The following is a description of a gene set: Human Gene Set: GSE11961_MARGINAL_ZONE_BCELL_VS_GERMINAL_CENTER_BCELL_DAY7_DN To obtain insight into the genetic basis of the increase of functional activity of memory B cells over time, we compared the gene expression profiles of day 7 and day 40 NP-specific/IgG1 memory B cells, GC B cells and plasma cells in immunized WT mice and naïve B cells, before and after activation in vitro. from publication Kaji T, Ishige A, Hikida M, Taka J, Hijikata A, Kubo M, Nagashima T, Takahashi Y, Kurosaki T, Okada M, Ohara O, Rajewsky K, Takemori T (PMID 23027924) Genes down-regulated in marginal zone B cells versus day 7 germinal center B cells. studied in species Homo sapiens, and this is the list of marker genes: CD151, RAP2A, LPIN1, RAB27A, MAPK3, CASP7 (caspase 7), ELL3, LRIG2 (leucine rich repeats and immunoglobulin like domains 2), SESTD1, SERPINE2, SH3RF1, ACOT4, TMT1A, TMCC3 (transmembrane and coiled-coil domain family 3), KRT26, RBL1, INCENP, SH3BGRL, FRYL, BARD1, PRKAB1, ANKHD1, NUDT12, CARHSP1, RAP1GAP2, DOCK2, FBXL2, PTPN9, TSC22D1, GZMA, BSPRY, PLEKHH1, ELMO2, RXRA, ARL4D, MAGOHB, CTSC, CD7, PRKRA, KIF1C, FARP2, STMN1, G6PC2, FAM81A, CRELD2, CAPN2, IL10RA, TMEM38B, MIB1, RAD51B, ANKLE1, CAPG, LUZP1, QKI, DENND2B, ARL5A, CHIC1, INO80D, OSBPL3, GFI1 (NCBI Gene Id 2672), PIK3CG, TF, FBH1 (F-box DNA helicase 1), FOXRED2, GABRQ, DZANK1, SEM1, CNOT11, FKBPL, KIF20B, FAM184A, TMBIM1, ASB2, RAD51, CLDN12, ZCCHC24, SORD, TASL, IL1A, POLH, RAPGEF2, PLEKHA2, PBK, RNF135, BAZ2B, RNPEP, TCEAL8, PRIM1, TYK2, FKBP5, ARHGEF7, NDUFB7, NUMBL, MED6, USP37, VAV3 (NCBI Gene Id 10451), ZNF768, NANS, CBFA2T3 (CBFA2/RUNX1 partner transcriptional co-repressor 3), EP300, SYNE3, GAS7, GNB5, PGGT1B, PROB1, TSFM, CCR5 (NCBI Gene Id 727797), GPR171, BORCS7, BAZ1A, PTPRJ, ZXDB, BRD3OS, CDC20B, GBP4, FAM53B, ASB1, FER, C4orf46, PANK2, CLTC, ATOSA, SCYL1, GATA3, LGALSL, TMEM171, KLRK1, LAMTOR3, PLIN2, TBK1, GRK5, TMEM51, SLA, FNDC4, REPS1, SSX2IP, CGAS, ANP32B (acidic nuclear phosphoprotein 32 family member B), NDNF, OR5D18 (NCBI Gene Id 81195), LPGAT1, TEX26, TTC39C, UBE2L3, RUNX3, TOMM6, BMPR2, NFKB1, TTK, ZC2HC1A, TPI1, PRKCB, PPIL2, CHKA, TRIO, WBP1L, DTNBP1, AKAP9, CHST11, TGFB3, ZNRF3, SCMH1, HSPA2, BET1, PTGR2, COPZ2, RAPGEF1, VIM, ACOT7, TFIP11, CBLL1, CEP135, SUZ12, CISD3, TRIM37, VPS4B, CXCL6, TIAM1, P4HB, SLC18B1, CYSLTR2, HDHD3, NCAPG, RPGR, TEX2, VMP1, SAP30, ANTXR2, GBP7, SLC35F5, ADAMTS1, HOATZ, ANXA9 (annexin A9), CBFA2T2, MYADM, IRAK2, EZH2, ZNF512, GAREM1, STK3